The following is a description of a gene set: Human Gene Set: GSE27786_NKCELL_VS_NKTCELL_UP from publication Konuma T, Nakamura S, Miyagi S, Negishi M, Chiba T, Oguro H, Yuan J, Mochizuki-Kashio M, Ichikawa H, Miyoshi H, Vidal M, Iwama A (PMID 21540074) Genes up-regulated in comparison of NK cells versus NKT cells. Each fraction of mouse hematopoietic cells was purified by cell sorting from bone marrow of 8-week-old C57BL/6 mice, and its gene expression was analyzed. studied in species Homo sapiens, and this is the list of marker genes: PTGIR, PTPRC (protein tyrosine phosphatase receptor type C, NCBI Gene Id 5788), DHRS4, IKBIP, RNF217, RPS6KA2, E2F7, LIMS4, SH3BGRL3, AGL, MINDY1, FRS3, F5, CRYAB, SUMF1, EXT1, CYP51A1, PPT2, SLC15A4, SPP1, SLC31A2, STK38, MYO1C, HDAC5, OSBPL1A, DHRS3 (dehydrogenase/reductase 3), MCTP1, DYNLT1, NMT1, ATRNL1, NOTCH2, STT3A, FYB1, ATG3, RAD51AP1, TMEM38B, AK2, YTHDF3, DUSP5, TNS3, RNF19B, ANAPC10, KLHL2, STK35, ACSS1, STARD5, SNX13, DUSP22, IRF2, ARF1, LTBR, RENBP, MKNK1, USP45, RWDD2A, HSD17B12, DHRS1, SCD, ATP9B, YWHAG, CMPK1, EIF1, MTHFR, AP3D1 (adaptor related protein complex 3 subunit delta 1), ZBTB18, GNB4, RAP1B, ZNF839, NFKBIZ, ZNF326, EBI3, KLHL30, FAR1, STYK1, EDEM3, PKIB, ATOX1, MSN, GINM1, POR, RASSF8, GSDMD, HMGCL, F13A1, P4HB, MBNL2, C14orf93, DIAPH3, TBC1D31, STK10, CMKLR1, ADIPOR1, CAPZA1, HLA-DMA, CHD9, ATG7, CA2, NIN, RALB, REL, MCCC2, GATM, VPS26A, HOMEZ, SNX9, LANCL2, ZDHHC9, SOX4, PLD4, TMEM179B (transmembrane protein 179B), ANO3, VAMP3, ARL13B, SCARB1 (scavenger receptor class B member 1), SORT1, TFG, NUDT13, TMPO, SOWAHC, EML6, CHID1, DENND6A, DHX58, PRAM1, NEK7, IRAK4, TM9SF4, CBR3, RNASE2, PTPN11, PRDX1, RASGRP2, DSTYK, ADGRE5, BET1, YWHAZ, MS4A2, TXN, CASP3, ORMDL2, FNDC3B, MAP4K3, TFEB, LMAN2L, DDX17, TMEM176B, MAP3K3, WASF2, CUZD1, NCR1 (natural cytotoxicity triggering receptor 1), JARID2, SOCS6, ACLY, CAMK1, ABHD12, PPP2R5A, ITGB5, TGFBR1, CAMKK2, SMC6, ANLN, PTPN1, CHML, BLOC1S2, GOLGA7, DCTN4, IGHM, ITPRIPL2, NFXL1, PSAP, FAM20C, VPS9D1, CSRP2, SERPINB1, ST8SIA4, MAP7D1, KPNA4, TMEM50B, ABCD1, PRF1, MIA2, CYBA, NFIC, OSBPL8, MAP1LC3A, MAP1LC3B, RGS19, CTNNA1, PRIMPOL, LAPTM5, CD2AP, PRKAB2, TNS4, PNP, PRDX4, EEF1AKMT1, SLAMF9, BNIP2, TRIB1, TMEM167B